The following is a description of a gene set: species: Mus musculus Mouse Gene Set: GOBP_DNA_BIOSYNTHETIC_PROCESS The biosynthetic process resulting in the formation of DNA., and this is the list of marker genes: Lin9, Smoc2, Xrcc5, Nox4, Pold4, Jade3, Rrm2b, Tk1 (thymidine kinase 1), Jade1, Pkib, Nppc, Ctc1, Lig4, Parn, Ptges3, Hrob, Rad50, Chtf8, Pnkp, Dtl, Polh, Chtf18, Pam16, Meaf6, Parp10, Poll, Rpa1, Dscc1, Hmbox1, Tep1, Ten1, Stn1, C3ar1, Crhr2, Sh2b1, Gja1, Poln, Ctnnb1, Adipoq, Rfc2, Rev1, Faap20, Dnajc2, Aurkb, Trex1, Tinf2, Ing5, Poli, Tfdp1, Kat7, Cct6a, Smpd3, Pdgfb, Pdgfrb, Rrm1, Ddx39b, Pold3, Egf, Niban2, Wnt3a, Tex12, Nop10, Gfer, Ing4, Gnl3l, Pclaf, Mapkapk5, Ptk2b, Cdkn2d, Spata22, Polq, Ankrd1, Ptges3-ps, Atm, Tert, Poldip2, Jade2, Htr2a, Nat10, Pot1b, Rfc3, Fgfr4, Pak3, Pinx1, Terf1, Nek2, Dach1, Lig3, Cyp1b1, Arrb2, Tk2, Tent4b, Rev3l, Cct5, Hnrnpd, Pold2, Gch1, Atr, Cct3, Exosc10, Sycp3, Sirt1, Dusp1, Prkd2, Chek1, Polm, Fbxo4, Vcp, Pole, Pcna, Cct2, Pole2, Terf2, Ahr (aryl-hydrocarbon receptor), Polg, Polb, Pold1, Mapk15, Fgf2, Gsk3b, Gar1, Rfc5, Map3k4, Primpol, Wrnip1, Sphk1, Terc, Lig1, Ccn2, Hnrnpc, Mad2l2, Vegfa, Dkc1, Hsp90aa1, Dcp2 (decapping mRNA 2), Rgcc, Phb1, Tnf, Zbtb1, Lox (NCBI Gene Id 16948), Sprtn, Wrap53, Polk, Cdkn1a, Parp4 (NCBI Gene Id 77419, poly (ADP-ribose) polymerase family, member 4), Mapk1, Pml, Pdgfa, Rgn, Tnks, Pola1, Sycp1, Trp53, Pot1a, Dntt, Prkcq, Polg2, Hgf, Ccna2, Camk2d, Tcp1, Cct7, Nek7, Chrac1, Hsp90ab1, Wrn, Acd, Map2k7, Rfc4, Pif1, Nfatc1, Src, Cct8, Kcnk2, Hnrnpu, Mapk3, Nhp2, Cct4